The following is a description of a gene set: Mouse Gene Set: GOMF_TRANSMEMBRANE_TRANSPORTER_BINDING studied in species Mus musculus Binding to a transmembrane transporter, a protein or protein complex that enables the transfer of a substance, usually a specific substance or a group of related substances, from one side of a membrane to the other., and this is the list of marker genes: Tcap, Ank2, Rapgef3, Tjp2, Actn1 (NCBI Gene Id 94278), Dlg1, Homer1, Bak1, Negr1, Diaph1, Ppm1a, Ank3, Gpd1l, Gopc, Smim43, Pde4d, Snta1, Slc5a3, Pacs2, Id2, Rnf207, Lrrc52, Nos1, Cib1, Ywhaq, Prnp (NCBI Gene Id 98923), Tcaf1, Stx1a, Hrc, Vamp2, Lrrc26, Sh3gl1, Cabp4, Lrrc38, Rims1, Atp1a1, Ctnnb1, Ap2m1, Casr (calcium-sensing receptor), Nherf1, Cabp1, Lyn, Kcnh1, Yes1, Pkd1, Kcnab1, Kcnq1, Tspo, Rasa1, Nptn, Kcnb1 (potassium voltage gated channel, Shab-related subfamily, member 1), Kcnq3, Atp2a3, Kcnip1, Tcaf3, Kcnip3, Rims4, Smim26 (small integral membrane protein 26), Phpt1, Kcnd3, Tcaf2, Itpr2 (inositol 1,4,5-triphosphate receptor 2), Kcne2, Hsp90ab1, Akap9, Camk2d, Pias3, Calm1, Ywhah, Cbarp, Fkbp1b, Kcnj11, Trappc2, Slc8a1, Scn10a, Kcnc2, Kcng4, Ppp2cb, Fkbp1a, Dynlt1f, Kcne3, Ppp1r9b, Hap1, Pacs1, Kcnb2, Fgf13, Tjp1, Stac, Lrrc55 (NCBI Gene Id 320555), Fhl4, Kcne1, Actn2, Kcne5, Kcnab3, Fmr1, Cav1, Trappc2b, Arrb1, Dpp10, Pkd2 (NCBI Gene Id 77380), Kcnip2, Pycard, Rims3, Fgf12, Vdac1 (voltage-dependent anion channel 1), Abcc8, Agrn, Ppp1r9a, Ywhae, Rims2, Calm3, Eif3e, Arl6ip5, Scn4b, Kcnc1, Iqschfp, Scn1b, Ywhaz, Actn4, Kcnh5, Dynlt1b, Abcc9, Kcne4, S100a10, Grina, Trp53, Cherp (calcium homeostasis endoplasmic reticulum protein), Lrrk2, Akap6, Cdh5, Dynlt1a, Prkcsh (protein kinase C substrate 80K-H), Mpp2, Fhl1, Trpc1, Herpud1, Tspan18 (NCBI Gene Id 69936, tetraspanin 18), Src, Actn3, Panx1, Bag2, Calm2, Htt, Fxyd1, Hsp90aa1, Scn5a, Pirt, Nedd4l, Snap25, Ank1, Cacna1c, Pkd2l1, Usp10, Itpr1, Lrg1, Epn1, Sh3gl2, Kcnab2, Tmem74, Flna, Dynlt1c, Ppp2ca, Crbn, Zfas1, Rangrf (RAN guanine nucleotide release factor), Pkd1l3, Rem1, Atp2a2, Trf (transferrin), Cav3, Scn3b, Fyn